The following is a description of a gene set: Human Gene Set: HP_COMPLETE_OR_NEAR_COMPLETE_ABSENCE_OF_SPECIFIC_ANTIBODY_RESPONSE_TO_TETANUS_VACCINE The inability to synthesize postvaccination antibodies against a tetanus antigen, as measured by antibody titer determination following vaccination. species: Homo sapiens Complete or near-complete absence of specific antibody response to tetanus vaccine, and this is the list of marker genes: MALT1, POLD1, ARHGEF1, CORO1A, AICDA, TNFRSF9, CD247, SEC61A1, ALG12, SHARPIN, CD81